The following is a description of a gene set: Mouse Gene Set: GOBP_TELENCEPHALON_GLIAL_CELL_MIGRATION studied in species Mus musculus The orderly movement of glial cells through the telencephalon., and this is the list of marker genes: Disc1, Cdk5, Dcx, Rtn4, Gli3, Dab1, Col3a1, Cdk5r2, Reln, Srgap2, Dab2ip, Socs7, Foxg1, Pafah1b1, Wdr47, Sun1, Zmiz1, P2ry12, Cdk5r1 (cyclin dependent kinase 5, regulatory subunit 1), Nr2e1, Ulk4, Syne2, Lrp8 (low density lipoprotein receptor-related protein 8, apolipoprotein e receptor), Adgrg1, Bmerb1, Sun2, Ctnnb1, Lamb1, Mboat7